The following is a description of a gene set: studied in species Mus musculus Catalysis of the reaction: 3'-phosphoadenosine 5'-phosphosulfate + a phenol = adenosine 3',5'-bisphosphate + an aryl sulfate. Mouse Gene Set: GOMF_ARYL_SULFOTRANSFERASE_ACTIVITY, and this is the list of marker genes: Sult1a1, Sult1d1, Sult1b1, Sult1c1, Sult1e1, Sult1c2